Given this list of marker genes OCA2, CLDN10, CAMTA1, FOXP1, NAA20, TNFSF4, ZBTB11, SATB1, SLC16A2, STAT4, NRXN1, PIGL, CHCHD10, ITGAM (NCBI Gene Id 3684), SPEN, PON1, POLR3B, TUBB2B, STRADA, SLC1A4, TBK1, SERPING1, SYNGAP1, SLC9A6, NEFH, IRAK1, TASP1, ETS1, DDC, TREX1, CHRM3, TSPOAP1, SQSTM1, LNPK, KCNC2, PTPN22, ADGRG1, PPARGC1A, CR2, UBE3A, ATP1A3 (ATPase Na+/K+ transporting subunit alpha 3), GABRG2, NOD2, SH3TC2, TAF15, PTS (NCBI Gene Id 5805), FOXP2, ZEB2, GNS, GSN, SPP1, PTPA, HPDL, HLA-DQB1, TLR7, KIF7, MED12, PON3, CCNF, PRPS1, MTHFS, ZNF365 (NCBI Gene Id 89878), ARX, DLK1, FGFR3, FGFR2, CHMP2B, SATB2, NTNG2, VAPB, NONO, UBQLN2, TBX1, CCR6, HERC1, SOD1, MBD5, PRPH, SIM1, BANK1 (B cell scaffold protein with ankyrin repeats 1), MECP2, GFM2, NALCN, CACNA1I, VAC14, ERBB4, GABRA1, NFIX, LBR, JAZF1, ANKLE2, SPTSSA, SNRPN, QDPR, PCGF2, SNAPC4 (NCBI Gene Id 80189), EDARADD, EXTL3, TTI1, HLA-B, SCN2A, POU3F3, TREM2, PDE10A, AP4E1, CLDN11, FBXO28, TANGO2 (transport and golgi organization 2 homolog), MATR3, GLT8D1, ELOVL1, PCDH19, GCH1, CTLA4, DNASE1, GPT2, DCTN1, GRIN2D, GRIN2A, PXK, SLC25A12, SLC9A7, AP4M1, TNFAIP3 (TNF alpha induced protein 3), VPS13A, HNRNPA1, MRE11, SCN1A, IKZF1, RAB11B, FBLN1, ATP6AP2, SMARCA2, SETD5, GABBR2, BCORL1, CERT1, PMP22 (peripheral myelin protein 22), TARDBP, HLA-DRB1, CHAMP1, KIAA0319L, DNM1L, CCN2, UBE2L3, PLA2G6, LMNB2, PDCD1, C4A, ATP10A, SCN9A, DLAT, HCRT, UNC13A (NCBI Gene Id 23025), GRIK2, ANG, CTSH, ZC4H2, DEAF1, ATRX, DAO, TAF4, ANXA11, C4B (NCBI Gene Id 721), RNU4-2, NAXD, SPTBN1, FCGR2B, PFN1, SRPX2, FCGR3B, PON2, MEG3, SPART, HDAC4, FIG4, POLR3A, ATXN2, CAV1, ITPR1, HIVEP2, RTL1, AP4B1, NEXMIF, SHMT2, TP63, TH, MOG, VCP, ALS2, TNIP1, HNRNPH2, NEK1, FUS, RSRC1, SLC12A5, FGF10, BLK, SCN1B, EIF2S3, AP4S1, PAK3, P2RY11, ATP7B, PI4KA, OPTN, IGHG1, MAGEL2, IL10, SLC12A2, KIF15 (kinesin family member 15), CFAP410, FOXG1, GLE1, IRF5, MED27, here is a description of the gene set: species: Homo sapiens Human Gene Set: HP_ABNORMALITY_OF_SALIVATION Abnormality of salivation